The following is a description of a gene set: studied in species Homo sapiens Foxp3+ T-regulatory cells (Tregs) are key to immune homeostasis such that their diminished numbers or function can cause autoimmunity and allograft rejection. Foxp3+ Tregs express histone/protein deacetylases (HDACs) that regulate chromatin remodeling, gene expression and protein function. Pan-HDAC inhibitors developed for oncology enhance Treg production and suppression but have limited non-oncologic applications given their broad effects. We show, using HDAC6-deficient mice and WT mice treated with HDAC6-specific inhibitors, that HDAC6 inhibition promotes Treg suppressive activity in models of inflammation and autoimmunity, including multiple forms of experimental colitis and fully MHC-incompatible cardiac allograft rejection. Many of the beneficial effects of HDAC6 targeting are also achieved by inhibition of the HDAC6-regulated protein, HSP90. Hence, selective targeting of a single HDAC isoform, HDAC6, or its downstream target, HSP90, can promote Treg-dependent suppression of autoimmunity and transplant rejection. Genes up-regulated in T reg: HDAC6 knockout versus wildtype. from publication de Zoeten EF, Wang L, Butler K, Beier UH, Akimova T, Sai H, Bradner JE, Mazitschek R, Kozikowski AP, Matthias P, Hancock WW (PMID 21444725) Human Gene Set: GSE27896_HDAC6_KO_VS_WT_TREG_UP, and this is the list of marker genes: EYA2, ABTB3, SNRK, INPP4A, DAP3, CAMKK1, EFL1 (NCBI Gene Id 79631), USP36, SIPA1, CREB1, SLCO4A1, TGIF1, MAX, PKNOX1, PATZ1, LRRC72, P3H4, STK4, ARID1B, SLC7A6, ATP2B1, ATXN7, TOMM34, APLP2, HEATR6, SPRED1, MED17, NR1D2, FAR1, PFKP, ARHGEF2, ATP9A (NCBI Gene Id 654090, ATPase phospholipid transporting 9A (putative)), MYO9A, MIER3, PUM1, SYNE3, THOC2, FOXN2, IL27RA, GFI1, POLG, LRRFIP1, ESYT2, AGFG1, PRR14, IVNS1ABP, KCNA2, LRCH1, COG1 (NCBI Gene Id 9382), PRKCD, RAMP1, ST13, INPP5D, GOLGA4, ARRB1, PTPRA, TSC22D4, ABTB2, MEX3C, PSD4, PTPN6, XPO7, GPR83, HOMER1, ARHGAP17, MYB, SEPTIN6, ZC3H12A, TNFRSF1A, PAPOLA, ATP1B1, GPATCH2L, HSPA4L, SS18L1 (SS18L1 subunit of BAF chromatin remodeling complex), TOX, TRIB2, COG3, CBLB, MAU2, TAOK3, IL21R, MYOF, HDAC10, KMT2E, XPR1, GARRE1, CD247, MAP3K8, TTC17, EPHX1, PAK2, PDE11A, JUP, SNX25, DLX4, PPRC1, SPATA13, UTRN, CAMK1G, ZSWIM4, KDM2B, IKZF1, NHERF1, GEM, TUBGCP4, ATG16L2, ITGA10, ZBTB10, UHRF2, PLCG1, HIVEP2, TCF7, ZHX2, SOCS1, WDR26, TBC1D20, ELL, RNF169, PPP6R1, NLRC3, NCOA1, PRDM15, RHBDL1, SFT2D1, VGLL4, SETX, IKZF3, PREP, NSUN4, KDM7A, SUN2, DUSP6, IZUMO1R, GIT2, KAT2B, PTGR3, CD99L2, MARF1, SPRY2, CNTNAP1, S100A11 (S100 calcium binding protein A11), GABPA, LEAP2 (NCBI Gene Id 116842), TSHZ1, PLEC, GALNT4, STRN, ADCY1, LDHB, PRKCH, ETV3, SLC41A1, ABI1, BAIAP2, PODXL2, CCL4, LTB, IL12RB1, KIF13B, HECW2 (HECT, C2 and WW domain containing E3 ubiquitin protein ligase 2), ADCY7, ABCA3, BRD2, PARP3, VAV1, ARHGEF18, SCAF8, PEAK1, IL17RA, NR2C2, H6PD, C1orf94, ITPKB, ELK4, OTUD5, SAFB (NCBI Gene Id 6294)